Given this list of marker genes PRKCG, GRIA3, AP2A1, GRIA2, GRIP2, AP2A2, GRIA4, PRKCB, GRIA1, PRKCA, AP2M1, GRIP1, PICK1, AP2S1, TSPAN7, AP2B1 (adaptor related protein complex 2 subunit beta 1), NSF, here is a description of the gene set: Trafficking of GluR2-containing AMPA receptors species: Homo sapiens Human Gene Set: REACTOME_TRAFFICKING_OF_GLUR2_CONTAINING_AMPA_RECEPTORS